The following is a description of a gene set: We demonstrated recently that both constitutive and FAS-triggered apoptosis of human neutrophils are profoundly impaired by Francisella tularensis, but how this is achieved is largely unknown. To test the hypothesis that changes in neutrophil gene expression contribute to this phenotype, we used human oligonucleotide microarrays to identify differentially regulated genes in cells infected with F. tularensis strain LVS compared with uninfected controls. In order to examine the effect of F. tularensis on the neutrophil transcriptome, we performed microarray expression analysis on human neutrophils treated with F. tularensis subsp. holarctica live vaccine strain (LVS). Genes up-regulated in comparison of control polymorphonuclear leukocytes (PMN) at 12 h versus PMN treated with F. tularensis vaccine at 48 h. species: Homo sapiens Human Gene Set: GSE37416_12H_VS_48H_F_TULARENSIS_LVS_NEUTROPHIL_UP from publication Schwartz JT, Bandyopadhyay S, Kobayashi SD, McCracken J, Whitney AR, Deleo FR, Allen LA (PMID 22986450), and this is the list of marker genes: STRN3, CNOT6L, MAPK1IP1L, P2RY2, ZNF277, YTHDC2, LGALS9, CBFB, SLC35B2, ECE1, RHOF, BANP (BTG3 associated nuclear protein), HCST, PTGES, FAM8A1, SMAD4 (NCBI Gene Id 4089), ZNF131, FHOD1, AREL1, LIMK2, TOP1, XKR8, MBD4, OLR1, MX2, OASL, IFNAR1, MAPK1 (NCBI Gene Id 5594), LRP10, RPS6KA5 (ribosomal protein S6 kinase A5), LYSMD2, RASGRP4, STK40, SNX18, ZNF641, CHIC2, ABRAXAS1, RAB11FIP4, CREM, CDKN2AIP, CDADC1, C2orf49, IMPA2, DEF6, GALNT1, SP100, NAB1, CRTC2, MAPKAPK2, MAP3K1, ISG20, SIPA1, STX6, OSBPL9, TAOK3, SPAG1, SERPINB1, TLR4, ADGRE5, MAP3K14, LCP1, STK38L, NBR1, SUPT4H1, BICRAL, PADI2, GOLM2, MIR21, TIA1, PLEKHM1, OSBPL11, CDK17, SAMD9, SIPA1L1, NFKBIE, LATS2, PPM1M, CLTB, SRXN1, KPNA3, L3MBTL3, PDLIM7, KCTD20, COQ2, PPM1D, INPP1, HERC5, ZNF410 (zinc finger protein 410), MIR23AHG, CEACAM3, TACC1, IRF9, TBC1D30, CUX1, CALM2, JDP2 (Jun dimerization protein 2), TMEM167B, SASH3, TM6SF1, RELT, TOP2B, LAT2, DR1, R3HDM4 (R3H domain containing 4), SPI1, LPGAT1, MAPRE1, GNMT, ADAM8 (NCBI Gene Id 101), TNFRSF1A, ERGIC1, NHSL2, NFKB1, HIRA, SPAST, MED21, ZNF710, TNFSF13B, F11R, CNOT6, USB1, HCK, PLCL2, RASSF5, IL4R, ATP2B4, ELF4, PTS, TOR1AIP1, NFKBID, SMURF1, PPP1R12A, CAB39, ARHGAP4, ARIH2, STIM2, PHTF1, SP110, GRIPAP1, LGALSL, TAB2, MLF2, DUSP1, MYH11, TAPT1 (transmembrane anterior posterior transformation 1), TMX4, INPP4A, ATP10D, FRYL, ATOSB (NCBI Gene Id 80256), RAB21, GIMAP4, AZIN1, ARAP3 (ArfGAP with RhoGAP domain, ankyrin repeat and PH domain 3), ZC3H12A, MCEMP1, DSE, PDE7A, CNPY3, YPEL5, TYROBP, SERTAD3, PLPPR2, MAP2K3, SERPINB9, MAP1LC3A, MAX, CUL4B, C1orf162, WDR26, PILRA, CD58, GK3, CRISPLD2, GMIP, SLC19A2, MX1, HARS2 (NCBI Gene Id 23438), TGIF2, DYNLT1 (NCBI Gene Id 6993), LRRC75A, DNAJA2 (NCBI Gene Id 9237), MYH9, CLIP1, HIGD1A, COP1, UBE2W, VAV3, MT1HL1, SIRPA, STK38, MANSC1, ZSWIM6, SNX10, PSME4, ZMYND15, CYLD, ACAA1, SKIL